Given this list of marker genes Nup155, Nup54, Lmnb1, Ndc1, Emd, Cdk1, Nup210 (nucleoporin 210), Seh1l, Rae1, Nup133, Ctdnep1, Nup205 (nucleoporin 205), Ccnb1, Nup58, Prkca, Nup93, Vrk1, Plk1, Nup42, Nup85, Aaas, Lmna, Vrk2, here is a description of the gene set: electronically inferred by orthology from the curated human pathway This event has been computationally inferred from an event that has been demonstrated in another species.<p>The inference is based on the homology mapping from PANTHER. Briefly, reactions for which all involved PhysicalEntities (in input, output and catalyst) have a mapped orthologue/paralogue (for complexes at least 75% of components must have a mapping) are inferred to the other species. part of: Mitotic Prophase Reactome Pathway: Nuclear Envelope Breakdown studied in species Mus musculus